Given this list of marker genes LIX1, HMGA2 (NCBI Gene Id 8091), MCM3, ZFP36L1, HEY1, HES1, here is a description of the gene set: Human Gene Set: ZHONG_PFC_HES1_POS_C1_NPC species: Homo sapiens from publication Zhong S, Zhang S, Fan X, Wu Q, Yan L, Dong J, Zhang H, Li L, Sun L, Pan N, Xu X, Tang F, Zhang J, Qiao J, Wang X (PMID 29539641)